The following is a description of a gene set: Human Gene Set: GSE37532_TREG_VS_TCONV_PPARG_KO_CD4_TCELL_FROM_LN_DN from publication Cipolletta D, Feuerer M, Li A, Kamei N, Lee J, Shoelson SE, Benoist C, Mathis D (PMID 22722857) studied in species Homo sapiens We identified Pparg as a major orchestrator of the phenotype of adipose-tissue resident regulatory T cells (VAT Tregs). To establish the role of Pparg in shaping the VAT Tregs gene profile and cell dynamics, Tregs from lymph nodes and visceral adipose tissue of mice sufficient and deficient of Pparg expression in Tregs were double sorted for microarray analysis. Genes down-regulated in lymph node from aged PPARG knockout mice: T reg versus T conv., and this is the list of marker genes: JAK3, TXLNA, TPP1, WDR3, AARSD1, CEP85L, GRPEL1, NIT2, PFAS, GTF3C6, INTS6L, ATP6V0E1, SCAMP3, XPO4, ERGIC2, NIFK, NT5DC3, DHX33, CCDC28B, RRS1, NHP2, RIOK2, TRAP1, SSR4, CCDC88B, CERS6, POP1, NCLN, RAB3GAP2, XPO5, ZNHIT6, RPS6KA1, MIOS, IER2, HSPA5, SLC39A14, MED28, SNU13, P4HB, TAF1D, MIR155HG, ZNF317, SHQ1, SYNGR2, EIF4G3, POLR1C, TYW1, CFAP97, PPAN, APEX1, SLC39A1, ICAM1, YIF1A, SMAGP, BABAM2, MRTO4, IFI30, POLB, CD83, TWNK, CYBA, ANKRD17, METTL1, PNP, CHST10, RUNX3, UBXN8, ANAPC1, RCL1, STAT3, SH2D2A, SNX9, MCCC2, RBM25, TSPAN31, NOPCHAP1, NR4A1, CCL4, TGFB1, NEDD9, EGR3 (NCBI Gene Id 1960), NXT1, PNO1, RHOG, KARS1, DNAAF5, RPP40 (NCBI Gene Id 10799), MYBBP1A, ABTB2, MTHFD1L, ZNRD2, SNORD104, TMEM138, EFR3A, PAK1IP1, DAP3, ADAM8, IKBKB, WDR74, DCTPP1, TRUB2, ACAA1, CLUH, NDUFAF4, ETF1, SSBP1, PUS3, KPNA6, RRP12, RPL7L1, PSME2, OTULIN, SLC11A2, EIF5, MRPL24, MYD88, WDR43, MOB3B, SEMA7A, LTBP3, NAPSB (NCBI Gene Id 92656), PTPN6, GAR1, LCP1, NOP14, PUM3, EFCAB14, KMO, PES1, EIF3G, MRPL12, ARPC4, USP36, NLE1, DNPEP, CHD4, UTP14A, MFSD1, NFKB1, GALNT7, TMEM223, CCDC86, WDR77, HIVEP3, IFRD2, EXOSC5, MKNK2, ZNF573, DDX21, SLC25A45, HYMAI, TIMM13, EIF5B, RPF2, BTG2, HSP90AB1, NAT10, MRPL20 (NCBI Gene Id 64994), EBI3, LYAR, LRRC32 (leucine rich repeat containing 32), PDIA6, ATP13A2, WSB1, ACY1, DIMT1, PHB1, PRMT1, ABCE1, EIF3J, HLA-F, PRDX4, ADAT2, DCUN1D5, MRRF, SLC35F2 (solute carrier family 35 member F2), CALR, TET3, EGR2 (early growth response 2), FAM98A, TM2D3, PMM2, PLSCR1, NOL6, CD40, CMSS1, HLA-J, TMEM123, JAM2, DNAH1, SRPRB, SNX11, RRP15, TM2D2, ZNF226, BCL3, NAMPT, TAP1 (NCBI Gene Id 92050), DUSP4